Given this list of marker genes WNT5A, MIR424, PRDM14, SULF1, MIR1-1, SPRY4, SPRY3, SULF2, MIR503, CREB3L1, APLN, MIR16-1 (NCBI Gene Id 406950), GPC1, GATA3, SHISA2, OFD1, MIR149, MIR573, NGFR, FGF2, WNT4, SPRY2, THBS1, FUZ, SPRY1, here is a description of the gene set: Human Gene Set: GOBP_NEGATIVE_REGULATION_OF_FIBROBLAST_GROWTH_FACTOR_RECEPTOR_SIGNALING_PATHWAY Any process that stops, prevents, or reduces the frequency, rate or extent of fibroblast growth factor receptor signaling pathway activity. studied in species Homo sapiens